Given this list of marker genes SMCHD1, UBE2D2, LINC03043, CSGALNACT2, MSI2, CCDC43, C14orf119, UCHL5, YES1, PDE8B, VPS26A, LEPR, WDR44, TIAL1, CTSC, ENPP2, SCN1A, ALG10B, BBX, CEP68, CNOT7, GCFC2 (NCBI Gene Id 6936), TXNDC16, SVEP1, ADAM12, MPP3, HCFC2, NRP1, COL9A1, AMELY, ACKR4, MYO6, TMEFF1, DYRK1A, SMAP1, DENND4C, RTP1, MAP2K4, SLC41A1, CDCP1, MAFB, ARPP21 (cAMP regulated phosphoprotein 21), SFPQ, HECW2, SLC38A2, TPPP3, ZNF347, XRN1, MEGF9, PRKRA, HNRNPAB, FTH1, ZCCHC2, TMEM179B (NCBI Gene Id 374395), HK1, CRAMP1, SCN2A, TMEM70, TMEM150A, ZNF217, TENT5C, TRIM59, PHLPP2, SEPTIN10, SLC25A21, TRMT6, NAP1L1, BMP6, SLC17A6, CDH2, ZMYM2 (zinc finger MYM-type containing 2), FYN, NR3C2, CREBBP, DOCK3, PIK3R3, RFX3, ARHGAP24, SRCIN1, UBE2G1, SIX1, CYFIP2, ARID1B, THAP2, ANGPTL7, PHF11, CAV2, MRPL35, DOCK9, PRKAA2, WDR17, STRN3, SLC25A26, DCN, TTC7B, AMD1, TFEC (NCBI Gene Id 22797), PAFAH1B1, SIAH1, SCN3A, SCYL3, MSANTD3-TMEFF1, KLF4, CD164, STAP1, PTHLH, KCTD17, TAB3, ZNF845, SON, KIAA1143, THEMIS, ARHGEF2, CREBRF, PTGFRN, DIXDC1, NEBL, EPN2, KITLG, CDH4, PLAGL1, ZNF780A, DYRK1B (dual specificity tyrosine phosphorylation regulated kinase 1B), ZFHX3, BCL3, MYB, FBXO11, PLPPR4, here is a description of the gene set: Human Gene Set: MIR150_3P studied in species Homo sapiens Genes predicted to be targets of miRBase v22 microRNA hsa-miR-150-3p in miRDB v6.0 with MirTarget v4 prediction scores > 80 (high confidence targets). from publication Chen Y, Wang X (PMID 31504780)